The following is a description of a gene set: studied in species Homo sapiens Human Gene Set: HP_BLISTERING_BY_HISTOLOGICAL_LOCATION Blistering by histological location Blistering (presence of multiple fluid filled blisters) categorized according to the layer of the skin in which the blister originates. The skin is divided into three layers. The epidermis (outermost layer, which mainly consists of keratinocytes), the dermis, and a subcutaneous layer. The epidermis is divided into five layers: the basal lamina (innermost layer), the basal cell layer, the stratum spinosum, the stratum granulosum, and the stratum corneum (outermost layer). Cleavage in epidermolysis bullosa (EB) simplex occurs within the basal keratinocytes; in junctional EB, within the lamina lucida; and in dystrophic EB occurs in the sublamina densa, in the upper portion of the dermis (papillary dermis). In Kindler's EB, cleavage can occur in the basal keratinocytes, in the lamina lucida, or below the lamina densa., and this is the list of marker genes: PLEC, CDSN, LAMC2, ITGB4, COL17A1, LAMA3, COL7A1, KRT14, LAMB3, ITGA6, KRT5, TGM5